Given this list of marker genes Tsg101, Zfyve28, Gprc5a, Zgpat, Socs4, Socs5, Chmp6, Psen2, Cblc, Vps25, Psen1, Errfi1, here is a description of the gene set: Mouse Gene Set: GOBP_NEGATIVE_REGULATION_OF_EPIDERMAL_GROWTH_FACTOR_ACTIVATED_RECEPTOR_ACTIVITY species: Mus musculus Any process that stops, prevents, or reduces the frequency, rate or extent of EGF-activated receptor activity.